The following is a description of a gene set: Mouse Gene Set: GOBP_REGULATION_OF_HETEROTYPIC_CELL_CELL_ADHESION studied in species Mus musculus Any process that modulates the frequency, rate, or extent of heterotypic cell-cell adhesion., and this is the list of marker genes: Lck, Skap1 (NCBI Gene Id 78473), Flot1, Fga, Alox15, Adipoq, Bmp7, Map2k5, Gcnt2, Cd44 (NCBI Gene Id 99339), Klf4, Wnk1, Mapk7, Ager, Il1b, Apoa1, Tnfaip3, Myadm, Tnf, Il10, Fgg, Fgb, Mbp, Il1rn